The following is a description of a gene set: from publication Constantinides MG, Picard D, Savage AK, Bendelac A (PMID 21632718) Microarray analysis was performed to determine the transcriptional profiles of NKT, CD1d-aGC+ Va24-, and CD4 T cells. species: Homo sapiens Genes up-regulated in NKT cells: naïve versus activated. Human Gene Set: GSE28726_NAIVE_VS_ACTIVATED_NKTCELL_UP, and this is the list of marker genes: PLA2G1B, ZBTB25, ESR1, CYP2D6, ZNF510, RALYL, ADA, JUNB, GUCA2A, KAT8, DGCR2, FCMR, PSD, SIT1, CTSW, KAT7, SOX4, CIZ1 (NCBI Gene Id 25792), GSTP1, MMP16, SRPK3, SNTA1, TSC22D3, PENK, GRHPR, INS, CEACAM7, BDH1, ADRA1A, ITGB2, IFIH1, TFDP2, ZNF500, NME3, HGFAC, GRIK3, TCAP, ZNF101, S1PR4, SMAGP, THEMIS2, CD302, H4C2, STX11, ALDH2 (NCBI Gene Id 217), PIP4K2B, RBFOX2, LPAR2, H2BC6 (NCBI Gene Id 8344), MED24, BTBD2, MYCNOS, HPGD, PADI2, ACTN3, MRNIP, RRP8, PCBP3, CXCL12, CYP3A5, ATP2A3 (ATPase sarcoplasmic/endoplasmic reticulum Ca2+ transporting 3), NRTN, MAPK11, ARTN, ZNF688, MAPK3, PLXNB3, ZFP36L2, PER1, ZMYND8, ACAA1, DNAJB1, GUCY2F, RELN, MCRS1 (NCBI Gene Id 10445), IRAK3, SAA1, CHD2, FNTB, AQP5, PAX6, SEC14L2, SLC25A42, IRF2BP1, BBLN, TPBG, ETHE1, THRA, RASA3, POU6F1, NCAPD2, OR2J2, PDLIM3, CPZ, DNAJB2, KAT2A, GADD45A, CLDN18, ULK2, SGK1, MDK, HLA-DOB, IMPDH1, GPI, ARHGEF11, GDPD5, TPX2, IKBKG, CXCR4, TPM1, CTNNBIP1, USP19, SLC9A3, CADPS (calcium dependent secretion activator), PIK3IP1, PIAS3, WWOX, TRAM2, TREX1, LHX2, MAP4K1, RPL14, LFNG, ERICH1, MINAR1, DGKA, NXPH4, SC5D, FAM161A, ERC1, NAGLU, TPM2 (tropomyosin 2), SPAM1, PLIN1, SUN2, CENPB, CDH3, FAM3A, SETD1B, ADCY9, HOXA5, RAB31, PARN, PFKL, CYBB, PXDC1, GGA2, FLOT2, RECQL5, ST3GAL1, CIT, FCER2, CA11, NTHL1, EYA2 (NCBI Gene Id 2139), UCHL1, FCHO1, CDH22, EN2, ID1, RBM38, SYP, H2BC10, PLCD1 (NCBI Gene Id 5333), TMSB10, RGS9, PYGM, SCN7A, SIK1 (salt inducible kinase 1), MEGF6, PIEZO1, TSN, PAPSS2, PPARD, ACVR2B, ACSBG1, SHOX (NCBI Gene Id 6473), FLRT1, TRIB2, KLF5, UBA7, CCDC57, PIM1, FGFR1, ARSL, ZNF174, GATAD1, PPP2R5D, TXNIP, NMBR, CPB1, SERPINB7, HDAC6, PLA2G4C, NCKIPSD, HERC2P3, MAP4K2, AIP, LILRA2